Given this list of marker genes USP24, GPSM2, FSD1L, U2SURP, PRMT6, HMCES, PPP3CB, ADGRE3, SMAD5, STAMBP, ARL5B, NLGN3, FZD8, LMNB1, MED14, LIPG, CA1, RAP2C, TFDP1, PON2, MCOLN3, STAG2, RBKS, NAP1L1, OTUD4, FCHSD2, TUT4, PALLD, HMBOX1, MTDH, TNKS, SAMD4B, USP25, CEP57, ASH1L (NCBI Gene Id 55870), DKK1 (NCBI Gene Id 22943), CDK19, WDR41 (WD repeat domain 41), RNF146, TMED4, TSPYL1, SF3B2, SOS2, LAMA4, SLCO1A2, B4GAT1, TGFBRAP1, HDX, FAM3C, SP3, CDC42EP3 (NCBI Gene Id 10602), CD93, DTNA, TAPT1, SCP2, FGFBP3, GEMIN5, HIVEP2, MAP3K2, RUBCNL, CDH11, FIGN, ANLN (anillin, actin binding protein), OSER1, CCDC93, UNC5D, PIK3C2B, USP45, MSL2, FOXO1, TBC1D32, OXR1, TBRG1, CCDC169-SOHLH2, WDR45B, PPP1R15B, DCAF10, PABPC4L, UBASH3B, CDY1B, ESCO1, KDSR, LONRF3, NUFIP2 (nuclear FMR1 interacting protein 2), WWC3, ST8SIA4, FOXJ2, ANKRD34C, HDAC8, SLC6A11, SPRED2, ZNF532, SINHCAF, MGAT4A, NAA30, TMEM263, LRRC7, ZBTB33, PRKAA2, ZBTB44, SRSF1, CAPS2, PIK3CA, SATB1, RAB3B, ZNF280D, FRMPD4, PEG10, EMC6, SLC25A24, BUB3, SCYL3, CELF4, TIAM1, ORC5, HELLS, C9orf152, NR2C1, RPRD1A, SLC16A9, PXK, UMAD1, IARS1, ZBTB41, MIGA1, ST6GAL2, RBMS1, FXR1, YWHAE, TBC1D24 (TBC1 domain family member 24), TOR1AIP2, MPL, SUSD6, MTFR1, HAS2, EPS8, UBE2W, PPP4R3A, CDY1, SLC25A16, GCA, NOX1, PRDM5, DACH1, MORF4L2, SUMO1, HELZ, ZDHHC17, DEPDC1, RAI14, FAM241A, UBLCP1, SLC25A32, HAUS1, HS6ST2, GIN1, PCNP, EEA1 (NCBI Gene Id 8411), OR7D2, ZNF728, PRKG1, RBM15B, TRIM67, here is a description of the gene set: species: Homo sapiens Genes predicted to be targets of miRBase v22 microRNA hsa-miR-4511 in miRDB v6.0 with MirTarget v4 prediction scores > 80 (high confidence targets). from publication Chen Y, Wang X (PMID 31504780) Human Gene Set: MIR4511